Given this list of marker genes TREM2, TNFAIP3, FANCD2, SHARPIN (NCBI Gene Id 81858), SLAMF1, FANCA, here is a description of the gene set: Human Gene Set: GOBP_REGULATION_OF_CD40_SIGNALING_PATHWAY studied in species Homo sapiens Any process that modulates the frequency, rate or extent of signaling via the CD40 signaling pathway.